The following is a description of a gene set: Mouse Gene Set: GOBP_NEURON_PROJECTION_REGENERATION The regrowth of neuronal processes such as axons or dendrites in response to their loss or damage. studied in species Mus musculus, and this is the list of marker genes: Mmp2, Jun, Apoa1, Fkbp1b (NCBI Gene Id 14226), Map2k1, Grn, Scarf1, Stk24, Adam17, Ctnna1, Xylt1, Kremen1, Apod, Nefl, Ulk1, Ptprf, Nefh, Tnr, Rtn4rl1, Lamb2, Enpp1, Ntrk3, Nrg1, Epha4, Mapk8ip3 (mitogen-activated protein kinase 8 interacting protein 3), Pum2, Ptprs, Map2k2, Prrx1, Adm, Dhfr, Dag1, Jak2 (Janus kinase 2), Ndel1, Lrig2, Bex1, Omg, Rgma, Ptn, Folr1 (folate receptor alpha), Nrep, Thy1, Igf1r, Rtn4, D130043K22Rik, Fas, Tspo, Cntf, Rtn4rl2, Flna, Pten, Lrp1, Mag (NCBI Gene Id 17136), Rtn4r, Apoe, Chl1, Map1b, Cspg5, Matn2, Diaph1, Gfap (NCBI Gene Id 14580), Mtr, Klf4, Neo1, Map4k4, Inpp5f, Bcl2 (B cell leukemia/lymphoma 2), Tnc, Diaph2, Apoa4, Rtca, Gap43, Braf, Cers2, Hgf